The following is a description of a gene set: Human Gene Set: REACTOME_TP53_REGULATES_TRANSCRIPTION_OF_CASPASE_ACTIVATORS_AND_CASPASES TP53 Regulates Transcription of Caspase Activators and Caspases species: Homo sapiens, and this is the list of marker genes: ATM, CASP6, CASP1, APAF1, CRADD, NLRC4, CASP10, PIDD1, TP63, CASP2, TP73, TP53